Given this list of marker genes Ptpru, Sh2b2 (SH2B adaptor protein 2), Ptpn11, Fyn, Sh2b3, Mmp9, Pik3ca, Fer, Lck, Src, Yes1, Kras, Sos1, Grap2, Pik3r3, Ptpn6, Grb7, Hras, Jak2, Grb10, Stat5a, Kitl, Lyn (NCBI Gene Id 99963), Pik3r2, Pik3r1, Stat5b, Cbl, Rac1, Chek1, Vav1, Cma1, Stat3 (signal transducer and activator of transcription 3), Grb2, Kit, Fes, Grap (GRB2-related adaptor protein), here is a description of the gene set: species: Mus musculus Signaling by SCF-KIT Mouse Gene Set: REACTOME_SIGNALING_BY_SCF_KIT